Given this list of marker genes PRMT1, SAMTOR (S-adenosylmethionine sensor upstream of mTORC1), MTOR (NCBI Gene Id 2476), MAT2A, NFE2L2, here is a description of the gene set: Human Gene Set: GOBP_CELLULAR_RESPONSE_TO_METHIONINE Any process that results in a change in state or activity of a cell (in terms of movement, secretion, enzyme production, gene expression, etc.) as a result of a methionine stimulus. species: Homo sapiens